The following is a description of a gene set: from publication Xie X, Lu J, Kulbokas EJ, Golub TR, Mootha V, Lindblad-Toh K, Lander ES, Kellis M (PMID 15735639) Genes having at least one occurrence of the highly conserved motif M137 GAANYNYGACNY in the regions spanning 4 kb centered on their transcription starting sites. The motif does not match any known transcription factor binding site. Comprehensive identification of all functional elements encoded in the human genome is a fundamental need in biomedical research. Here, we present a comparative analysis of the human, mouse, rat and dog genomes to create a systematic catalogue of common regulatory motifs in promoters and 3' untranslated regions (3' UTRs). The promoter analysis yields 174 candidate motifs, including most previously known transcription-factor binding sites and 105 new motifs. The 3'-UTR analysis yields 106 motifs likely to be involved in post-transcriptional regulation. Nearly one-half are associated with microRNAs (miRNAs), leading to the discovery of many new miRNA genes and their likely target genes. Our results suggest that previous estimates of the number of human miRNA genes were low, and that miRNAs regulate at least 20% of human genes. The overall results provide a systematic view of gene regulation in the human, which will be refined as additional mammalian genomes become available. studied in species Homo sapiens Human Gene Set: GAANYNYGACNY_UNKNOWN, and this is the list of marker genes: TMEM71, NFATC4, CACNA1G-AS1, TRMT2A, GSPT1 (G1 to S phase transition 1, NCBI Gene Id 2935), HSD11B1, DEXI, GSE1, PGAM2, IGF2BP1, CDK14, NAV1, FGF23, SLC1A1, NR4A2, UBE2K, JOSD1, FOXN1, ESRRB, SEM1, USP37, SULF1, DNAJA2, TLE3, SHC1, PLPPR1, ONECUT2, SEC24D, NR2F1, GDA, INTS5, BABAM2, RAB25, PAX6, GRID2 (glutamate ionotropic receptor delta type subunit 2), RANBP1, PNKD, TP63, TENT2 (terminal nucleotidyltransferase 2), APH1A, BEND4, ZNF485, SPOCK2, ARMCX6, CCDC50 (coiled-coil domain containing 50), STK4, UBE2Z, CDC14A, HHEX, TCF12, MINK1, PLAC1, SUMO1, MYL1, TMEM59L, FOXN3, STAT3, TSPAN13, LRFN4, CDIN1, SCN4A, CDKN1A, SP4, NR2C2, ART1, IGF1 (insulin like growth factor 1), ZNF641, CKS1B, HTN1, ZHX2, MID1, CEP97, CARMIL1, NR2F2, COL15A1, CNOT9